Given this list of marker genes COG8, CCDC88A (coiled-coil domain containing 88A), MGAT2, STAMBP, GOT2, MDH1, MPC1, ARFGEF2, TREX1, PYCR2, SEPSECS, RNASEH2C, TSEN54, TOE1, CLP1, RNU4-2, BRAT1, ACBD5, QARS1, NDUFS1 (NADH:ubiquinone oxidoreductase core subunit S1), DPM2, EXOSC3, RARS2, EXTL3, ALG9, EXOSC8, PPT1, EFTUD2, TSEN2 (tRNA splicing endonuclease subunit 2), PCDH12, FAR1, COG1, WWOX, ERCC6, ERCC8, MECP2, POMK, CDKL5, DIAPH1, COG7, PLAA, MFSD2A, FOXG1, SLC2A1, CDC45, ALG1, PNKP, ATP6V1E1, GOLGA2, VRK1, SPTAN1, CDC42, GLYCTK, ACO2, SLC25A46, AGTPBP1, ALG12, DOLK, PUS3, PAFAH1B1, BCKDK, SCN8A, VARS1, SMPD4, ZNHIT3, CASK, TRAPPC6B, CC2D1A, LAMB2, ATP6V1A, PNPO (pyridoxamine 5'-phosphate oxidase), SLC1A4, VPS53, GRIA2, LGI3, IQSEC2, SNAP29 (NCBI Gene Id 9342), NAPB, ZSWIM6, TSEN34, CNP, ASNS, PTRH2, SLC39A14, RNF113A, TSEN15, EMC1, ATP6V0A2, RNASEH2A, PCLO, EXOSC9, TUBGCP2, here is a description of the gene set: Human Gene Set: HP_PROGRESSIVE_MICROCEPHALY Progressive microcephaly Progressive microcephaly is diagnosed when the head circumference falls progressively behind age- and gender-dependent norms. studied in species Homo sapiens